Given this list of marker genes PPP3R1, PRKAR2A, CFLAR, TPBG, SPATA2, IFI30, CDSN, PLAUR, ATP6V1F, PPP2R2A, ZNF148, ZNF10, FAM210B, SHISA7, FZD10, ANKRD40, ZEB1, PRSS16 (NCBI Gene Id 10279), ZFP14, RIOX2 (ribosomal oxygenase 2), GRIK5, GTF3C3, UBE3C, DCAF12L1, RETREG3, HSF4, CHMP5 (charged multivesicular body protein 5), CDH12, FAM47E-STBD1 (FAM47E-STBD1 readthrough), HIF1AN, CLEC4G, SULT1E1, CEP170, LHX6, KCNJ13, BEST3, COL25A1, F2RL2, CCBE1, AHCYL2, LSAMP, PCM1, PIPOX, POU2F3, ZNHIT3, ADORA3, IKZF5 (NCBI Gene Id 64376), MMP2, FRMD4B, LAMA3, SLC8A2, RSF1, CDH7, MFSD4A, MIER1, STRN4, NKD1, XPR1, TLCD5, MLLT10, ANKRD34A (NCBI Gene Id 284615), CIR1, SUGP2, MORC1, SOS1, TMPRSS5, EFEMP1, GBX2, NOX4, SOX8, CRACDL, here is a description of the gene set: from publication Chen Y, Wang X (PMID 31504780) Human Gene Set: MIR12115 species: Homo sapiens Genes predicted to be targets of miRBase v22 microRNA hsa-miR-12115 in miRDB v6.0 with MirTarget v4 prediction scores > 80 (high confidence targets).